The following is a description of a gene set: HTLV-1 Tax to spindle assembly checkpoint signaling. Pathway ID: N00221. Pathway type: Pathogen. Pathway class: nt06230 Cell cycle. Pathway Definition from KEGG: TAX -> (ANAPC+CDC20) -| PTTG -| ESPL1 Human Gene Set: KEGG_MEDICUS_PATHOGEN_HTLV_1_TAX_TO_SPINDLE_ASSEMBLY_CHECKPOINT_SIGNALING studied in species Homo sapiens, and this is the list of marker genes: ANAPC2, ANAPC1, ANAPC7, ANAPC13, ANAPC11, ANAPC5 (anaphase promoting complex subunit 5), CDC26, CDC16, CDC23, CDC27, ANAPC4, PTTG1, PTTG2, ANAPC10, ESPL1, CDC20